The following is a description of a gene set: Mouse Gene Set: REACTOME_UB_SPECIFIC_PROCESSING_PROTEASES studied in species Mus musculus Ub-specific processing proteases, and this is the list of marker genes: Ar, Psmb3, Tada3, Usp34, Usp26, Smad3, Psmd8, Psma4, Polb, Psmd12, Usp4, H2ac22, Ubc, Usp14, Psmd1, Tada2b, Usp25, Psmd2, Ripk1, Ikbkg, Siah2, Suds3, Usp10, H2ac4, Psmb7, Usp16, Il33, Traf2, H2ac24, Adrm1, Psmd13, H2ac21, Mat2b, Psmc4 (proteasome (prosome, macropain) 26S subunit, ATPase, 4, NCBI Gene Id 23996), Rnf123, Tnks2, Usp12, Usp20, Cyld, Psmc1, Foxo4, Usp33, H2ac11, Birc3, Cftr, Ccp110, Usp2, Cdc20, Psmb4, Usp11, Taf10, Smurf2, H2ac7, Usp22, Psmd3, Usp3, Usp29, Usp44, Becn1, Adrb2, Usp17lc, Axin1, Cdc25a, Skp2, Psma3, Wdr48, H2ac23, Tnks, Rnf128, Mdm4, Ptrh2, Rigi, H2ac18, Tomm70a, Usp7, Usp17lb, Pten, H2ac6 (NCBI Gene Id 319164), Psmb6, H2ac19, Traf6, Rhot1, Gata3, Usp19, Vdac2, Trp53, Usp21, H2ac25, Otub1, Usp17la, Arrb1, H2ac20, Mul1, Tab1, Tomm20, Keap1, Stam2, Usp28, Ufd1, Snx3, Usp48, H2ac15, Smad7, Clspn, Usp9x, Psmb5, Psmb2, Usp8, Psma7, Psmd7, Rnf146, Psmd14, Psma1, Taf9b, Uba52, Atxn7, Vdac3, Tgfbr1, Usp5, Ddb2, Psmc3, Axin2 (NCBI Gene Id 12006), Usp47, H2ac10, Rps27a, Usp15, Psma6, Psmd11, Psmc5, Psma5, Nfkbia, Smad4, Arrb2, Hif1a, Smad2, Wdr20, H2ac13, Psmb1, Usp18, Usp37, Psmc2, Ide, Myc, Usp30, Psmd6, Ccna1, H2ac12, Usp24, Uba52rt, Usp17ld, Mdm2, Rce1, Hgs, Psma2, H2aj, Trrap, Vdac1, H2ac8, Usp17le, Ubb (ubiquitin B), Fkbp8, H2ac1, Ccna2, Kat2a, Birc2, Psmc6, Ifih1, Usp13, Usp42, Ruvbl1, Map3k7, Smad1